The following is a description of a gene set: Genes up-regulated in dendritic cells: untreated versus 8h after infection of Leishmania major. from publication Favila MA, Geraci NS, Zeng E, Harker B, Condon D, Cotton RN, Jayakumar A, Tripathi V, McDowell MA (PMID 24808365) Leishmania major infected human dendritic cells (DCs) exhibit a marked induction of IL-12 ultimately promoting a robust Th1-mediated response associated with parasite killing and protective immunity. In this study, we utilized Affymetrix Genechips to globally assess the host cell genes and pathways associated with L. major infection during early infection (2, 4, 8, and 24 hrs) in human myeloid-derived DCs. Bioinformatic analyses of the hybridized microarray chips identified genes, represented by 848 unique probe sets, which, when compared to uninfected samples were observed to be significantly differentially expressed by one-way ANOVA. Altogether, the data provide a genome-wide perspective on the transcriptional influences Leishmania species exert within human DCs during early infection, and provides a platform for further investigations toward functionally characterizing candidate genes of importance to the IL-12 based immune response to infections. In the current study, we further investigate the L. major infected DC transcriptional during early time points after infection via microarray analysis. Human Gene Set: GSE42088_UNINF_VS_LEISHMANIA_INF_DC_8H_UP species: Homo sapiens, and this is the list of marker genes: MT2A, CD209, NT5E, PLGRKT (plasminogen receptor with a C-terminal lysine), GGH, FLRT2, CLEC4A, UCK2, CHI3L1, GPR137B, VAC14, AFDN, WNT5A, C1orf54, SLAMF8, FSCN1 (fascin actin-bundling protein 1), CXCL5, RRS1, SCG5, C1QTNF1, CISH, WDR3, MT1G, FJX1, ATP2C1 (ATPase secretory pathway Ca2+ transporting 1), ACP2, CYP27A1, ZMYND8, TSEN2, BMAL2, GLYR1 (glyoxylate reductase 1 homolog), CD1E, LAPTM4B (lysosomal protein transmembrane 4 beta), ZMIZ2, HSP90AA1, CCL1, MAGOHB, NETO2, TMEM38B, FGGY, ADO, PLCL1, AGRN, FCGR2B, LRP8, NSUN3, LAMP3, LSS, MICA, NF1, RMI1, PIR, GART, DSC2, FBP1, VWA8, APOO, TNS3, ADGRE3, CCL17, ZNF573, ABCC3, CD1A, NRP1 (NCBI Gene Id 8829), MMP10, MT1E, NISCH, BRIX1, STEAP3, PAICS, LIMA1, CCL24, CYP27B1, CXCL1, MKNK1, TMEFF1, PRDX4, ETV5, NT5DC2, CCL22, CSTF3, SLC1A3, POMT1, TFRC, NDP, MTX2, NR1H3, NDRG2, SLC38A6, PPAT, SMAGP, SEPTIN10, POLR2H, CD1C, FTL, MT1M, AP1AR, FUT8, MT1HL1, PUS7, UGGT2 (NCBI Gene Id 80239), INHBA (NCBI Gene Id 3624), IDO1, UGDH, TNIK, KIF1B, MT1X, SYT17, GSN, OLFML2B, BHLHE41, PIGN, CREBL2, PRR16, PI3, ACO1, PDPN, CXCL6, MREG, GBA1LP, P2RY6, TUBB, ATP6V0B (ATPase H+ transporting V0 subunit b), MYO1E, POP1, FKBP4, HSPA8, EEF1AKMT3, ZBTB6, MAF, SLC33A1, PLTP, MRTO4, CCDC86, TUBB4B, ADAMDEC1 (ADAM like decysin 1), GTDC1, FN1, ATOX1, GPHN, LRP12, PSMB5, ENPP2, CRIM1, TSFM (NCBI Gene Id 10102), GLA, GREM1, METTL1, N6AMT1, STXBP1, HMGA2 (NCBI Gene Id 8091), CD1B, PLXNA1, NHLRC2, MT1H, CPM, SLC25A13, MMP9, CCL19, VSIG4, MAOA, DHCR24, PTPRE, MINPP1, PPA2, ARL1 (ADP ribosylation factor like GTPase 1), MRC1, RAB13, SCARF1, CXCL13, FAM200C, MT1F, C3, TFPI2, TCEAL9, PRMT5, MMP14, SIGLEC7, SPATS2L, C2CD3, TGFBI, HSD11B1, CD81, PRKCA, ZNF804A, TNIP3, PROCR, ARMT1, LTBP2 (NCBI Gene Id 83981), CTNS, SLCO2B1, SLC39A6, STAC, NME1, UBA5, EBI3, RTN2, NEFH, EXOSC4, CDK5RAP2